Given this list of marker genes HINT1, GDAP1, FLNC, PMP22, MPV17, TIMM8A, MPZ, NGLY1, MORC2, HSPB3, RYR1, KLHL9, DYSF, VCP, JAG1, CAV3, CHRNA1, HARS1, CHCHD10, TRIM2, PDK3, LDB3, SLC12A6, KIF1A, TIA1, SPTLC1, SQSTM1, PRX, SVBP, here is a description of the gene set: Human Gene Set: HP_INTRINSIC_HAND_MUSCLE_ATROPHY studied in species Homo sapiens Atrophy of the intrinsic muscle groups of the hand, comprising the thenar and hypothenar muscles; the interossei muscles; and the lumbrical muscles. Intrinsic hand muscle atrophy